The following is a description of a gene set: studied in species Mus musculus The series of molecular signals initiated by an extracellular purine nucleotide binding to its receptor, and ending with the regulation of a downstream cellular process, e.g. transcription. Mouse Gene Set: GOBP_PURINERGIC_NUCLEOTIDE_RECEPTOR_SIGNALING_PATHWAY, and this is the list of marker genes: P2rx1, P2ry2 (NCBI Gene Id 18442), P2ry4, P2ry6, Adora3, Acp3 (acid phosphatase 3), Ada, P2rx2, Necab2, Adcy5, Gnai2, P2rx3, Oxgr1, P2ry14, Hcar2, P2ry12, Adora2a, P2rx6, Ano6, P2ry1, Adora2b, Adora1, Gpr87, P2ry13, P2rx7, Cntn2, P2rx4